Given this list of marker genes TRAPPC2L, SAR1B, CUL3, TRAPPC2, MAP4K2, SEPTIN5, TFG, EXOC4 (exocyst complex component 4), EXOC6, ARFGAP3, TRAPPC8, STARD3NL, EXOC2, TRAPPC11, ARFGAP2, TRAPPC2B, AP1AR, TBC1D23, STARD3, TRAPPC12, NLGN1, TRAPPC5, PDCD6, PSEN1, PEF1, SEC16A, SAR1A, WIPI1, TMED9, MAPK15, FAM91A1, TRAPPC13, TRAPPC6A, CSNK1D, TMED2 (transmembrane p24 trafficking protein 2), TRAPPC6B, IRAG2, CLASP1, CLASP2, KLHL12, TMED10, SCRIB, NAGLU, TRAPPC3, PREB, TRAPPC1, SNAP23, EXOC1, EXOC6B, YKT6, SNAP29, EXOC8 (NCBI Gene Id 149371), TRAPPC4, TRAPPC9, EXOC5, EXOC3, AP1M2 (NCBI Gene Id 10053), GBF1, PPP6C, TRIP11, CEP19, WDR11, C17orf75, EXOC7, TRAPPC10, here is a description of the gene set: Human Gene Set: GOBP_VESICLE_TARGETING The process in which vesicles are directed to specific destination membranes. Targeting involves coordinated interactions among cytoskeletal elements (microtubules or actin filaments), motor proteins, molecules at the vesicle membrane and target membrane surfaces, and vesicle cargo. studied in species Homo sapiens